Given this list of marker genes AGO2, AGO3, AGO1, TNRC6B, TNRC6A, AGO4, TNRC6C, here is a description of the gene set: species: Homo sapiens part of: Gene Silencing by RNA Reactome Pathway: Post-transcriptional silencing by small RNAs Small RNAs act with components of the RNA-induced silencing complex (RISC) to post-transcriptionally repress expression of mRNAs. Two mechanisms exist: 1) cleavage of target RNAs by complexes containing Argonaute2 (AGO2, EIF2C2) and a guide RNA that exactly matches the target mRNA and 2) inhibition of translation of target RNAs by complexes containing AGO2 and an inexactly matching guide RNA or by complexes containing a nonendonucleolytic Argonaute (AGO1 (EIF2C1), AGO3 (EIF2C3), or AGO4 (EIF2C4)) and a guide RNA of exact or inexact match. Small interfering RNAs (siRNAs) and microRNAs (miRNAs) can serve as guide RNAs in both types of mechanism. <br>RNAi also appears to direct chromatin modifications that cause transcriptional gene silencing.